Given this list of marker genes NFYB, CPT2, MED15 (mediator complex subunit 15), HMGCS1, MED12, TIAM2, APOA1, MED14, MED9, TBL1XR1, MED20, NRF1, SULT2A1, APOA2, HMGCR, MED17, MED13L, G0S2, ABCA1, MED11, RXRB, TRIB3, UGT1A9, MED8, MED27, SREBF1, ME1, ESRRA, NFYA, AHRR, MED25, ACADM, ANKRD1, CPT1A, AHR, ARNT2, FDFT1, CYP4A11, NR1D1, CYP7A1, CDK8, MED30, GRHL1, AGT, NCOA3, NPAS2, MED18, TBL1X, PPARGC1A, RGL1, MED13, MED26, CHD9, RORA, MED19, PEX11A, ANGPTL4 (NCBI Gene Id 93954), FAM120B, CD36, FADS1, NCOA6, MED4, NR1H2, FHL2, PLIN2, CARM1, MED24, PPARGC1B, NCOR1 (nuclear receptor corepressor 1), HMGCS2 (3-hydroxy-3-methylglutaryl-CoA synthase 2), MED21, CYP1A1, PPARA, TXNRD1, CCNC, PPARG, SP1, GPS2, NFYC, NCOR2, HDAC3, HELZ2, MED29, MED6, MED31, SMARCD3, TNFRSF21, SLC27A1, MED28, THRAP3, EP300, BMAL1, MED16, MED23, MED7, ALAS1, MED22, MED10, ACSL1, CREBBP, ACOX1 (acyl-CoA oxidase 1), ABCB4, FABP1, ARNT (aryl hydrocarbon receptor nuclear translocator), NR1H4, RXRA, TGS1, NCOA1, NR1H3, APOA5, GLIPR1, NCOA2, SREBF2, MTF1, MED1, CLOCK, CDK19, here is a description of the gene set: part of: Regulation of lipid metabolism by PPARalpha The set of genes regulated by PPAR-alpha is not fully known in humans, however many examples have been found in mice. Genes directly activated by PPAR-alpha contain peroxisome proliferator receptor elements (PPREs) in their promoters and include: <br>1) genes involved in fatty acid oxidation and ketogenesis (Acox1, Cyp4a, Acadm, Hmgcs2);<br>2) genes involved in fatty acid transport (Cd36,, Slc27a1, Fabp1, Cpt1a, Cpt2);<br>3) genes involved in producing fatty acids and very low density lipoproteins (Me1, Scd1);<br>4) genes encoding apolipoproteins (Apoa1, Apoa2, Apoa5);<br>5) genes involved in triglyceride clearance ( Angptl4);<br>6) genes involved in glycerol metabolism (Gpd1 in mouse);<br>7) genes involved in glucose metabolism (Pdk4);<br>8) genes involved in peroxisome proliferation (Pex11a);<br>9) genes involved in lipid storage (Plin, Adfp).<br>Many other genes are known to be regulated by PPAR-alpha but whether their regulation is direct or indirect remains to be found. These genes include: ACACA, FAS, SREBP1, FADS1, DGAT1, ABCA1, PLTP, ABCB4, UGT2B4, SULT2A1, Pnpla2, Acsl1, Slc27a4, many Acot genes, and others. Reactome Pathway: PPARA activates gene expression studied in species Homo sapiens